The following is a description of a gene set: Catalysis of the transfer of a methyl group to a DNA molecule. studied in species Mus musculus Mouse Gene Set: GOMF_DNA_METHYLTRANSFERASE_ACTIVITY, and this is the list of marker genes: N6amt1, Dnmt3a, Dnmt1, Dnmt3b, Mettl4, Dnmt3l